Given this list of marker genes DECR2, CYP4F2, FABP3, PEX5, HADHB, GDF15, SOX9 (NCBI Gene Id 6662), ACAA2, APOD, ACOX1, AKT1 (AKT serine/threonine kinase 1), ALOX12B, PEX13, MCAT, ADH7, ETFBKMT, ACOXL, PLIN5, HADH, FMO2, POR, PRKAA1, ADIPOR2, ETFB, AKT2, ALDH1L2, ACOT8, ECHDC2, IRS1, ADH4, HAO2, HSD17B10, ACAT1, MLYCD, ACOX2, PHYH, ACAD10, CRAT, TYSND1, MAPK14, ALOX12, APPL2, PPARA, PLA2G7, ACADVL, ACAD11, ETFA, ALOX15B, CYP4V2, IVD, PPARGC1A, PEX2, ACSM1, BDH2, SESN2, KLHL25, ADIPOR1, LEP, PRKAG2, SLC27A2, SLC25A17, HSD17B4, FMO1, DGAT2 (NCBI Gene Id 84649), EHHADH, ECHS1, ECI2, CPT1B (NCBI Gene Id 150414), ETFDH, SAMD1, ACADS, ALOXE3, GCDH, AMACR, SCP2, HAO1, CROT, ABCB11, MTLN, CYGB, DECR1, ACOX3, TWIST1, SIRT4, ABCD3, HACL1, ECI1, FMO4, ABCD2, CPT2, ABCD4, ILVBL, ECH1, LONP2, PEX7 (peroxisomal biogenesis factor 7), ADH5, ACADM, ECHDC1, PPARD, ACADL, MFSD2A, PDK4, ACACB, CPT1A, IRS2, ABCD1, ACAA1 (acetyl-CoA acyltransferase 1), ALOX15, ADIPOQ (NCBI Gene Id 9370), CYP4F3, ABCC9, ALOX5, HADHA, AUH, here is a description of the gene set: species: Homo sapiens Human Gene Set: GOBP_LIPID_OXIDATION The removal of one or more electrons from a lipid, with or without the concomitant removal of a proton or protons, by reaction with an electron-accepting substance, by addition of oxygen or by removal of hydrogen.